The following is a description of a gene set: Catalysis of the reaction: CTP + H2O = CDP + H+ + phosphate. May or may not be coupled to another reaction. Human Gene Set: GOMF_CTPASE_ACTIVITY species: Homo sapiens, and this is the list of marker genes: ENTPD1 (ectonucleoside triphosphate diphosphohydrolase 1), ABCE1, ENTPD7, ENTPD4 (NCBI Gene Id 9583), NTPCR, DDX3X